Given this list of marker genes Tmem164, Gpx4, Slc7a11 (solute carrier family 7 (cationic amino acid transporter, y+ system), member 11), Sqstm1, Sc5d, Slc39a7 (solute carrier family 39 (zinc transporter), member 7), Hmox1, Fth1, Nfe2l2, Ninj1, Aifm2, Nqo1, here is a description of the gene set: species: Mus musculus Mouse Gene Set: GOBP_FERROPTOSIS A programmed cell death characterized morphologically by the presence of smaller than normal mitochondria with condensed mitochondrial membrane densities, reduction or vanishing of mitochondria crista, and outer mitochondrial membrane rupture. Activation of mitochondrial voltage-dependent anion channels and mitogen-activated protein kinases, upregulation of endoplasmic reticulum stress, and inhibition of cystine/glutamate antiporter are involved in the induction of ferroptosis. This process is characterized by the accumulation of lipid peroxidation products and lethal reactive oxygen species (ROS) derived from iron metabolism. Glutathione peroxidase 4 (GPX4), heat shock protein beta-1, and nuclear factor erythroid 2-related factor 2 function as negative regulators of ferroptosis by limiting ROS production and reducing cellular iron uptake, respectively. In contrast, NADPH oxidase and p53 act as positive regulators of ferroptosis by promotion of ROS production and inhibition of expression of SLC7A11 (a specific light-chain subunit of the cystine/glutamate antiporter), respectively. Misregulated ferroptosis has been implicated in multiple physiological and pathological processes.